The following is a description of a gene set: studied in species Mus musculus Mouse Gene Set: GOBP_SODIUM_ION_HOMEOSTASIS Any process involved in the maintenance of an internal steady state of sodium ions within an organism or cell., and this is the list of marker genes: Drd2, Corin, Scnn1a, Sgk1, Mllt6, Atp12a, Slc8a1, Comt, Atp1a4, Slc9b2, Atp1b1, Slc9a1, Scnn1g, Atp1b3, Ednrb, Atp1a2, Fxyd2, Scn7a (NCBI Gene Id 99039), Ext2, C7, Agt, Tesc, Edn1, Il1a, Ext1, Atp6v1b1, Mc3r, Ednra, Tmprss3, Spx, Atp4b, Scnn1b, Upk3a, Atp4a, Umod, Atp1a1, Atp1b2, Atp1a3, Slc1a3, Slc12a3 (NCBI Gene Id 20497), Nr3c2, Spp1, Slc12a2, Agtr2, Slc12a1